Given this list of marker genes CDCA3, SGO2, TUBB4B, ZNF521, KIF2C, MDC1, TAB2, CCNB1, GLI1, HMG20B, JPT1, PIK3CD, FGA, RCBTB2, HSPA13, PRR11, INSM1, PTPN9, KLF9, HCFC1, NCOA5, HP1BP3, STAT5B, PBK, KIF14, CENPA, RANGAP1, TNFAIP8L1, PIMREG, BUB1, BIRC2, ADH4, HMMR, KLHDC9, LRRC17, HSPA8, RNF126, CDC27, POC1A, CNN2, PTP4A1, ZC3HC1 (NCBI Gene Id 51530), RCAN1, CDKN2D, TRIP13, HMGB3, C6, CSGALNACT1, SLC44A2, ODF2, MKI67, BIRC5, PYM1, VANGL1, ME3, POM121, NUSAP1, QRICH1, MCM4, TNPO1, ZMYM1, LRP8, CCDC88A, RBM8A, MIS18BP1, MTCL2, CREBRF, TSN, TSKU, TFF3, G2E3, CNTROB, DZIP3, SLC17A2, ADM5, KMT5A, CENPE, NDE1, RASGEF1A, SRD5A1, SPDL1, GPSM2, PRPSAP1, GTSE1 (G2 and S-phase expressed 1), LPP, DR1, ASPHD2, LBR, PSMG3, CCNA2, NUF2, DEPDC1, ARHGDIB, DLGAP5, TTK, PRR5, TSG101, IDO1, CCSAP, DEPDC1B, B4GALT1, GAS6, HSPA1L, TXNDC9, SPAG5, CDC42EP1, PLK1, SS18, KIF5B, THRAP3, CCND1, ANLN, CFLAR, TPX2, ARL6IP1, ANP32B, FOXM1, GADD45A, ATF7IP, NUP35, LMNA, ZFX, RNF141, TMCO4, ARHGAP19, AFDN, TOMM34, NEK2, GRK6, DUSP4, MATN2, CDC25B, ATXN1L, TXNRD1, SHCBP1, ASXL1, E2F5, ANP32E, USP13, RNPS1, PLAG1, CKAP5, INPP5K, RAD51C, PCF11, OLR1, CENPF, WSB1, CEP55, TGIF1, ADGRE5, PPP1R10, CKAP2, SMARCB1, PATJ, DNAJA1, KCTD2 (potassium channel tetramerization domain containing 2), USP16, SPTBN1, CKS1B, GOT1, NUP98, CKS2, HERPUD2, GSE1, ECT2, SAPCD2, CCNB2, PTGER3, HPS4 (HPS4 biogenesis of lysosomal organelles complex 3 subunit 2), BUB1B, CTNND1, TMEM138, KNSTRN, AURKA, JADE2, DNAJB1, KIF20B, SMTN, CTNNA1, OIT3, SFPQ, FRZB, FYN, BMP2, AHI1, MZT1, IDI2, SELENON (NCBI Gene Id 7800), GAS2L3, RRP1, SMARCD1, KMT5B, YWHAH, SRSF3, ITPR1, MAPK13, AKIRIN2, here is a description of the gene set: Human Gene Set: WHITFIELD_CELL_CYCLE_G2_M studied in species Homo sapiens Genes periodically expressed in synchronized HeLa cells (cervical carcinoma), with peak during the G2/M phase of cell cycle. The genome-wide program of gene expression during the cell division cycle in a human cancer cell line (HeLa) was characterized using cDNA microarrays. Transcripts of >genes showed periodic variation during the cell cycle. Hierarchical clustering of the expression patterns revealed coexpressed groups of previously well-characterized genes involved in essential cell cycle processes such as DNA replication, chromosome segregation, and cell adhesion along with genes of uncharacterized function. Most of the genes whose expression had previously been reported to correlate with the proliferative state of tumors were found herein also to be periodically expressed during the HeLa cell cycle. However, some of the genes periodically expressed in the HeLa cell cycle do not have a consistent correlation with tumor proliferation. Cell cycle-regulated transcripts of genes involved in fundamental processes such as DNA replication and chromosome segregation seem to be more highly expressed in proliferative tumors simply because they contain more cycling cells. The data in this report provide a comprehensive catalog of cell cycle regulated genes that can serve as a starting point for functional discovery. The full dataset is available at http://genome-www.stanford.edu/Human-CellCycle/HeLa/. from publication Whitfield ML, Sherlock G, Saldanha AJ, Murray JI, Ball CA, Alexander KE, Matese JC, Perou CM, Hurt MM, Brown PO, Botstein D (PMID 12058064)